Given this list of marker genes SEC61A2, CCNYL1, CERS2, ZFTA, RND2, USP20, COL4A2 (NCBI Gene Id 1284), IFI16, MATCAP2, ZNF669, CYP2R1 (NCBI Gene Id 79445), ABLIM2, CHAC1, QSER1, TMEM170B, CCDC184, FBXL12, PAK5, KLHDC8B, FAM87A, TIGD7, SNX7, NCOR2 (nuclear receptor corepressor 2), RAP2A, KIAA0753, BRSK1 (NCBI Gene Id 84446), SEMA4B, ANGPT1, CBLN2, ST8SIA3, SMAP1, SLC6A15, DNAAF9, KCTD1, LRCH2, RFTN1, ZNF70, IGF2R, TIPRL, ZNF805, TMTC2, RAB3B, IFNAR1, TMEM245, CYFIP1, PDZD2, HTN3, MTMR3, ZDHHC21, PLSCR1, ZNF776, NAT1, CYFIP2, NDFIP1, CDS2 (CDP-diacylglycerol synthase 2), USP33, SGCB, PCDH7, RCAN1, HIVEP1, MZF1, RNF157, CTPS2, FARP2, CDK19, ZNF512, S100A13, SLC35C2, DCHS1, WSB1, ST3GAL5, ARK2C, MAGEH1, ACP6, FAM193A, IL24, NALF1, IRGQ, PPP1R3C, SETDB1, SRCIN1, DDAH2, PTK2B, MBTPS2, ARL8A, PSAP, SCG2, ATP6V1H, GPR85, PART1, PTOV1, CHIC1, GPRASP2, PI4KA, ZNF558, PTCH1, RAI14, ZNF592, CELF6, COLQ, HSPA1A, VEZT, ARMCX1 (NCBI Gene Id 51309), PAFAH1B3, IRF5, PPP1R21, IL13RA1, KLF3, NINL, RAP1GAP2, REC8 (REC8 meiotic recombination protein), CYTH2, KCTD5, CSDC2, STMN2, PTGR3, CLASP1, UBE2F, INA, CORO1A, KRT18, RASGRF1, SMAGP, CREBRF, CCNA1, ATP1A3, TLCD3B, SIRT2, FAM171A1, NCAM1, RAB6A, ALS2 (alsin Rho guanine nucleotide exchange factor ALS2), TBC1D23, CNKSR2, FAM78B, ARHGAP29, ARMC8, PHC2, B3GNT5, MYD88, HOXC9 (NCBI Gene Id 3225), REEP1, STXBP1, DDR1, C1R, KATNIP, PGM2L1, SYNE1, ENSG00000284634, PHYHIP, STRADB, PLD2, WDR33, RAPGEFL1, DYRK4, TTC39C, TH, EXTL2, NICOL1, DYNLT1, ENO2, ENTPD4, MAP4K4, EVC, GSTM3, NACAD, GDAP1L1, SEL1L2, HGSNAT, RNF208, PALM, SMARCE1, DLX5, TM4SF1, CD200, LINC00937, IFNGR2, RTN2, AZIN1, SVOP, METRNL, AMOTL2, PNMA1, SLC26A11, VWDE (von Willebrand factor D and EGF domains), SCD, ZNF177, ATCAY, RABGEF1, EID2B, TTC13, MAST1, PDZK1, ZNF354C, HAPSTR1, KAZN, here is a description of the gene set: studied in species Homo sapiens Tumor growth is associated with a profound alteration of myelopoiesis, leading to recruitment of immunosuppressive cells known as myeloid-derived suppressor cells (MDSCs). Analyzing the cytokines affecting myelo-monocytic differentiation produced by various experimental tumors, we found that GM-CSF, G-CSF, and IL-6 allowed a rapid generation of MDSCs from precursors present in mouse and human bone marrow (BM). BM-MDSCs induced by GM-CSF+IL-6 possessed the highest tolerogenic activity, as revealed by the ability to impair the priming of IFN- -producing CD8+ T cells upon in vivo adoptive transfer. Moreover, adoptive transfer of syngeneic, GM-CSF+IL-6-conditioned MDSCs to diabetic mice transplanted with allogeneic pancreatic islets resulted in long term acceptance of the allograft and correction of the diabetic status. Cytokines inducing MDSCs acted on a common molecular pathway. Immunoregulatory activity of both tumor-induced and BM-derived MDSCs was entirely dependent on C/EBP transcription factor, a key component of the emergency myelopoiesis triggered by stress and inflammation. Adoptive transfer of tumor antigen-specific CD8+ T lymphocytes resulted in therapy of established tumors only in mice lacking C/EBP in myeloid compartment. These data unveil another link between inflammation and cancer and identify a novel molecular target to control tumor-induced immune suppression. We used gene expression analysis to identify those factors, secreted by tumor-infiltrating MDSC, which could drive emathopoiesis. Moreover we compare gene expression profile of tumor-induced MDSC, obtained from either the spleen and the tumor infiltrate of tumor bearing mice, and in vitro bone marrow-derived MDSC. Human Gene Set: GSE21927_SPLEEN_VS_BONE_MARROW_MONOCYTE_BALBC_UP Genes up-regulated in CD11b+ cells from BALB/c mice: spleen versus bone marrow. from publication Marigo I, Bosio E, Solito S, Mesa C, Fernandez A, Dolcetti L, Ugel S, Sonda N, Bicciato S, Falisi E, Calabrese F, Basso G, Zanovello P, Cozzi E, Mandruzzato S, Bronte V (PMID 20605485)